Given this list of marker genes Mettl23, Prmt9, Prmt2, Prmt5, Prmt1, Carm1, Prmt6, Prmt8, Ndufaf7, here is a description of the gene set: species: Mus musculus Mouse Gene Set: GOMF_HISTONE_H3R17_METHYLTRANSFERASE_ACTIVITY Catalysis of the reaction: S-adenosyl-L-methionine + (histone H3)-arginine (position 17) = S-adenosyl-L-homocysteine + (histone H3)-N-methyl-arginine (position 17). This reaction is the addition of a methyl group to the arginine residue at position 17 of histone H3.